Given this list of marker genes SEPTIN5, SEPTIN11, SEPTIN8, SEPTIN12, SEPTIN1, SEPTIN9, SEPTIN2, SEPTIN6, SEPTIN10 (septin 10), SEPTIN7, MAPKAPK5, SEPTIN3, SEPTIN14, SEPTIN4, MAPK6, here is a description of the gene set: The part of the cytoskeleton (the internal framework of a cell) composed of septins and associated proteins. Includes septin cytoskeleton-associated complexes. studied in species Homo sapiens Human Gene Set: GOCC_SEPTIN_CYTOSKELETON